The following is a description of a gene set: Mouse Gene Set: GOCC_PARALLEL_FIBER_TO_PURKINJE_CELL_SYNAPSE An excitatory synapse formed by the parallel fibers of granule cells synapsing onto the dendrites of Purkinje cells. species: Mus musculus, and this is the list of marker genes: P2rx6, Cbln3, Gnao1, Pclo, Kcnh1, Ppp3r1 (NCBI Gene Id 19058), Cntn6 (contactin 6), Scn8a, Grid2, Slc1a6, Synj1, Pfn1, Snap91, Cadps2, Kcnj9, Slc16a7, Kcnj6, Ctnna2, Plcb4, Grin2a, Atp2b2, Kcnj3, Slc6a9, Stxbp1, Gnb5, Ppfia4, Cadm3, Gpm6a, Gria3, Slc16a3, Susd4, Grin2b, Grin1, Unc13c, Atp2b3 (NCBI Gene Id 320707), Cbln1, Mgll, Sptbn2, Grid2ip, Picalm, Calb2, Grm4, Tmem240